The following is a description of a gene set: part of: Signaling by MET Reactome Pathway: MET activates RAS signaling species: Homo sapiens Activated MET receptor recruits the RAS guanyl nucleotide exchange factor (GEF) SOS1 indirectly, either through the GRB2 adapter, GAB1 or SHC1 and GRB2, or RANBP9. Association of SOS1 with the activated MET receptor complex leads to exchange of GDP to GTP on RAS and activation of RAS signaling.<br>PTPN11 (SHP2) may contribute to activation of RAS signaling downstream of MET.<br>Sustained activation of MAPK1 (ERK2) and MAPK3 (ERK1) downstream of MET-activated RAS may require MET endocytosis and signaling from endosomes.<br>Binding of MET to MUC20 or RANBP10 interferes with RAS activation., and this is the list of marker genes: MUC20, NRAS, GRB2, SHC1, SOS1, HGF, RANBP9, KRAS, HRAS, RANBP10, MET